The following is a description of a gene set: Neddylation Mouse Gene Set: REACTOME_NEDDYLATION studied in species Mus musculus, and this is the list of marker genes: Ube2d1, Fem1b, Spsb2, Fbxo11, Fbxl21, Ubb (ubiquitin B), Fbxo30, Fbxo9, Ube2d3, Psmd1, Spsb3, Fbxo7, Ube2d2a, Fbxl7, Dcun1d3, Klhl9, Klhl13, Nedd8, Btbd6, Spsb4, Lrrc41, Cops3, Commd8, Commd9, Fbxw4, Ccnf, Dcaf13, Ufd1, Socs5, Fbxw7, Fbxw8, Fbxl14, Psmb4, Psmc3, Psmd2, Kctd7, Tulp4, Psma4, Dcaf5, Fbxw5, Dda1, Elob, Fbxl12, Psma6, Skp1, Kbtbd8, Asb5, Ddb1, Fbxl20, Asb12, Commd7, Psmd11, Cish, Nae1, Rps27a, Wdr5, Cops6, Cul4a, Cops7a, Commd1, Vhl, Klhl25, Psmd13, Fem1c, Fbxo2, Cop1, Cul1, Nub1, Fbxo4, Fbxo17, Klhl2, Uchl3, Fbxo44, Skp2, Ubxn7, Kctd6, Gps1 (G protein pathway suppressor 1), Lmo7, Rbx1 (NCBI Gene Id 80401), Socs2, Commd2, Psmd8, Dcun1d4, Klhl3, Ubd, Fbxl3, Psmb5, Asb9, Klhl11, Dcaf4, Rnf7 (NCBI Gene Id 19823), Fbxo22, Dcun1d5, Wsb1, Klhl41, Fbxl5, Btbd1, Neurl2, Fbxo32, Fbxw11, Cops5, Psma7, Ubc, Psmb6, Fbxw2, Epas1, Ankrd9, Psmd6, Fbxl4, Commd3, Rbbp5, Socs3 (NCBI Gene Id 12702), Psma2, Asb16, Dcaf11, Asb4, Nploc4, Fbxw10, Psmc4, Psma3, Klhl42, Asb14, Fbxo40, Uba52, Asb6, Dcaf10, Asb10, Fbxl19, Psmc6, Commd4, Eloc, Gan, Kbtbd13, Asb13, Commd5, Cops7b, Klhl21, Dcun1d2, Psmb3, Dcaf6, Fbxl13, Senp8, Hif3a, Asb17, Hif1a, Fbxw9, Dcaf8, Psma1, Ercc8, Psmb2, Fbxo10, Cul4b, Cops8, Wdtc1, Spsb1, Klhl22, Psmd3, Commd10, Fbxo21, Kbtbd7, Dtl, Fem1a, Cand1, Adrm1, Socs6, Dcaf17, Asb7, Mul1, Ube2m, Wsb2, Psmd7, Rbbp7, Psmc1 (NCBI Gene Id 19179), Psmb7, Cops4 (COP9 signalosome subunit 4), Fbxl16, Cul3, Vcp, Asb1, Asb8, Fbxw17, Asb11, Uba52rt, Fbxo27, Cul2, Fbxo41, Fbxl8, Dcaf7, Klhl5, Keap1, Psmd12, Ddb2, Fbxo6, Commd6, Psmc2, Psma5, Cops2, Psmd14, Nfe2l2, Fbxo15, Fbxl18, Dcun1d1 (defective in cullin neddylation 1 domain containing 1), Lrr1, Ccdc22, Psmb1, Psmc5, Fbxl15, Uba3, Ube2f, Fbxo31, Klhl20, Asb18 (ankyrin repeat and SOCS box-containing 18)